The following is a description of a gene set: species: Homo sapiens Any process in which an organism voluntarily modulates its posture, the alignment of its anatomical parts. Human Gene Set: GOBP_NEUROMUSCULAR_PROCESS_CONTROLLING_POSTURE, and this is the list of marker genes: GLRA1, TMEM150C, GBX1, SLURP1, LARGE1, TCF15, CLN8, SCN1A, GCH1, ATP8A2, GAA, PNKD, MECP2, POU4F1, ADARB1, CNTNAP1, PRRT2, FXN, HEXA